Given this list of marker genes Foxc1, Heyl, Bcl2, Hey1, Notch1, Tbx20, Alx1, Hey2, here is a description of the gene set: The process aimed at the progression of a mesenchymal cell over time, from initial commitment of the cell to its specific fate, to the fully functional differentiated cell. species: Mus musculus Mouse Gene Set: GOBP_MESENCHYMAL_CELL_DEVELOPMENT